Given this list of marker genes PCCB, HLA-DRB1 (NCBI Gene Id 730415), PML, PRF1, TBL1XR1, DHFR, IKZF1, ACD, NLRC4, ADA2, TALDO1, SRP72, IVD, DPP9, COG6, ATR, FANCE, TERT, FANCA, SBDS (SBDS ribosome maturation factor), NAXD, RECQL4 (RecQ like helicase 4), UBE2T, TNFRSF4, DCLRE1B, FIP1L1, RAP1B, LYST, HOXA11, TCIRG1, THPO, ELANE, ZNF699, NABP1, CIITA (NCBI Gene Id 4261), ZBTB16, CUBN, PCCA, GATA2, BACH2, SAMD9, JAK2, CALR, DUT (deoxyuridine triphosphatase), RFX5 (NCBI Gene Id 5993), CLPB, FANCC, STAT3, MAN2B1, GBA1, TET2, PSTPIP1, SRP19, RAC2, FANCD2, BCOR, OSTM1, TINF2, LRBA, NRAS, WRAP53, SF3B1, GALE, NBN, XIAP, CA2, TNFSF11, PSMB9, ASXL1, CBL, FARSB, PALB2, SP110, MTRR, RNASEH2A, DNAJC21, GNAS (NCBI Gene Id 82944), SCARB2, HAVCR2, COQ2 (coenzyme Q2, polyprenyltransferase), ACP5 (acid phosphatase 5, tartrate resistant), RARA, TCF3, NPM1, CD27, RFXANK, MPL, IFIH1, XRCC4, SRSF2, ITCH, TNFRSF9, SLX4, SRP54, RPA1, LMBRD1, MMAA, NUMA1, TERC, EFL1, KRAS, SAMD9L, PIGA, IFNG, STAT5B, DKC1, PRKAR1A, SARS2, LIG4, SMARCAL1, ITK, ANAPC1, IRF2BP2, MRPS7, ACBD6, DNASE2, STN1, AMN, GFI1, PTPRC, TCN2, MTHFD1, SH2D1A (SH2 domain containing 1A), NOP10, RAB27A (NCBI Gene Id 5873), SLC46A1, RFXAP, FANCB, NHP2, RUNX1, MMAB, ALPK1, here is a description of the gene set: Human Gene Set: HP_PANCYTOPENIA An abnormal reduction in numbers of all blood cell types (red blood cells, white blood cells, and platelets). studied in species Homo sapiens Pancytopenia